Given this list of marker genes SAE1, RWDD3, UBA2 (ubiquitin like modifier activating enzyme 2), SUMO1, SUMO2, SUMO3, UBE2I, here is a description of the gene set: Human Gene Set: REACTOME_SUMO_IS_TRANSFERRED_FROM_E1_TO_E2_UBE2I_UBC9 SUMO is transferred from E1 to E2 (UBE2I, UBC9) studied in species Homo sapiens